The following is a description of a gene set: Upslanted palpebral fissure Human Gene Set: HP_UPSLANTED_PALPEBRAL_FISSURE studied in species Homo sapiens The palpebral fissure inclination is more than two standard deviations above the mean for age (objective); or, the inclination of the palpebral fissure is greater than typical for age., and this is the list of marker genes: ASXL1, MRPS2, NBN, PIGV, KDM5C, PIGW, HUWE1, UQCC2, UBE2A, SETD2, EXOC2, DHCR7, PYCR2, SLC30A9, CHAMP1, DVL3, ADARB1, QRICH1, IFT140 (intraflagellar transport 140), HNRNPU, CTU2, TBX1, ERCC4, DYRK1A, DDB1, HECTD4, CDK13, ZIC2, AP1S1, SPEN, H3-3A, PGAP1, PRKAR1B, PHC1, PEX16, PEX26, BPTF, SMS, HERC2, IGF1R, COG7, PEX14, MKRN3, RDH11 (NCBI Gene Id 51109), ZNF292, NFIX, FANCL, PEX11B, PMM2, PIGO, RREB1, VAC14, ZMYND11, ANKLE2, ANK1, SPTBN1, PEX6, CDC42, PWAR1, EHMT1, GNB2, SMC1A, MAD2L2, FANCA, UBE2T, MTSS2, CREBBP, WBP4, SNORD116-1, TRIP12, SETD5, CIT (citron rho-interacting serine/threonine kinase), FANCG (FA complementation group G), COG1, SEPTIN9, MEF2C, LIG4, WWOX, UBAP2L, PEX10, PARS2, NCAPD3, PGAP3, PIGY, GJA5, POLR3A, KIF14, FGFR2, ALX4, BICRA, ZNF148, RAB11B (RAB11B, member RAS oncogene family), ESAM (NCBI Gene Id 90952), DONSON, PEX1, COMT, EBF3, NARS1, TLK2, EXOSC2, TRIO, CENPE (NCBI Gene Id 1062), JMJD1C, KDM4B (NCBI Gene Id 23030), MED13L, WDR62, H4C5, FANCE, PRDM13, MEIS2, NDUFS4, TRRAP, POLR3GL, PGAP2, GAD1, SLX4, BRCA2, ERI1, NXN, NSDHL, TUBGCP2, LMNB1 (NCBI Gene Id 445266), FZD2, ROR2, MAPRE2, PEX3, WARS1, CNTNAP2, NOG, PWRN1, PQBP1, OCRL, ANKRD17, LMBRD2, NR2F1, RERE, PIGL, PLPBP, POLA1, PPP1R12A, RAI1, CD96, B3GLCT, EP300, PEX2, NONO, BLTP1, PEX13, TAF4, ZNF526, JAG1, SNORD115-1, RNU4-2, AGR2, ITPR1, COL3A1, TOE1, POLR1A, TCF4, FANCD2, CASP2, HIRA, TOR1A, PTCH1 (NCBI Gene Id 8015), FANCB, ASPM, TBCD, PHF8, IFT57, MAP3K7, TMCO1 (transmembrane and coiled-coil domains 1), CCDC22, CDC42BPB, HDAC4, TFAP2A, KAT8, FANCF, CEP152, RAP1B, RIPK4, WNT5A, AHDC1, PHIP, DVL1, WDR26, COG8, BRCA1, DLX4, RTTN, EBP, NSD2, NUP37, MFSD2A, ARVCF, ZC4H2, PCDHGC4, CHD5, ATAD3A, NFIA, PAK3, KANSL1, TRAPPC10, GATAD2B, FBXO31, USP9X, HBB, ABL1, TRAPPC14, ADAT3, HSD17B4, DPYD, NPAP1, GJA1, PEX19, IL1RAPL1, GATA4, ADNP, FANCM (NCBI Gene Id 57697), BRIP1, STEEP1, ATRX, KNL1 (kinetochore scaffold 1), U2AF2, DLG3, COPB1, SCNM1, PIGN, PEX5, CDK6, ACBD6, ACTB, H4C3, HS2ST1, CACNA1G, FIG4, MCPH1, RAD21, BUB1B, POGZ, ASXL3, PEX7, PPP1R21, CLTC, ADAMTS3, RFWD3, CERT1, CCDC32, TBX6, DHX9, XRCC4, H4C11, AGO2, KIF11, PIGT, HNRNPR, MECP2, METTL5, IFT56, ANKRD11, EIF4A2, WDR35, RFX7, EXTL3, PUF60, PALB2, CHD4, CNOT2, SIM1, MEGF8, MAPK8IP3, MAF, TELO2, COPB2, TBCK, RAD51, MCTP2 (multiple C2 and transmembrane domain containing 2), CEP63, BCL11B, MCM7, PCNT, TAF13, C2CD3, FGFR1, IQSEC2, ZFX, UBE3B, THOC6, SEC24C, ADAMTSL2, XRCC2, CEP135, ZMIZ1, PEX12, NRCAM, CTCF (CCCTC-binding factor), CEP295, SNRPN, ALG2, DYNC1I2 (NCBI Gene Id 1781), SPECC1L, DEAF1, SARS1, HERC1, UBR1, CDK5RAP2, CNOT3, AP3B1, FANCI, FLII, FLNA, EFTUD2, FANCC, PPP1CB, PIGA, MAGEL2, PURA, HHAT, GJA8, STIL, DPH5, WASF1, EIF2AK3, JARID2, TUBB, SASS6, RAD51C, MYCN, GP1BB, PIGB, MINPP1, HIVEP2, TRPM3, TGDS, UFD1, ARID1B, AUTS2